The following is a description of a gene set: Catalysis of the endonucleolytic cleavage of RNA, removing 5' extra nucleotides from tRNA precursor. Mouse Gene Set: GOMF_RIBONUCLEASE_P_ACTIVITY studied in species Mus musculus, and this is the list of marker genes: Rpp21, Pop5, Prorp, Rpp14, Rpp25, Rpp40, Pop1, Pop4, Rpp30, Pop7, Rpp38